The following is a description of a gene set: Human Gene Set: MIR6803_5P from publication Chen Y, Wang X (PMID 31504780) Genes predicted to be targets of miRBase v22 microRNA hsa-miR-6803-5p in miRDB v6.0 with MirTarget v4 prediction scores > 80 (high confidence targets). species: Homo sapiens, and this is the list of marker genes: PRKCA, LARP4, HCN2, IGF2, CPN2, ZNF32, CRTC1, CFLAR, ELK4, RACGAP1, C17orf107, CTBS, ADAR, GSTM4, LHX6, LIMK1, PPP6R2, STX1B, CBX6, DAGLA, PRKCG, AMPH, SLC45A3, ZFAND1, ZNF701, MRPL3, ZSWIM4, SPRR1B, ACTB, SCRT2, ASB4, NFIC, GNA14, MAGI3, MEIS2, CLIP3, RAB3A, COL1A1, SSC5D, ANKRD60, LDHA, CCDC186, ZBTB7A, IGDCC3, ALKBH1, KRTAP17-1, TBC1D30, NALF2, KIF4B, FOXP4, ZNF474, ZDHHC15, CITED2 (Cbp/p300 interacting transactivator with Glu/Asp rich carboxy-terminal domain 2), DNAJB5